Given this list of marker genes AKAP5 (NCBI Gene Id 9495), RAB11FIP3, ABHD17A, TFRC, ABHD17B, ZDHHC2, here is a description of the gene set: Human Gene Set: GOCC_POSTSYNAPTIC_RECYCLING_ENDOSOME_MEMBRANE studied in species Homo sapiens The lipid bilayer surrounding a postsynaptic recycling endosome.